Given this list of marker genes Mios, Sec13, Sik3, Gpr137 (G protein-coupled receptor 137), Ogt, Fnip2, Klhl22, Otub1, Rps6kb1, Tbk1, Lamtor4, Wac, Bmt2, Mat2a, Cul3 (cullin 3), Rbx1-ps, Slc38a9, Wdr59, Fnip1, Rheb, Ctns, Usp32, Rbx1, Pim1, Ep300, Otud5, Lamtor1, Flcn, Sesn2, Shq1, Stambpl1, Syk, Rragb, Gpr137c, Pih1d1, Srms, Lamtor5, Akt1, Rragc, Prmt1, Src, Lars1, Lamtor2 (NCBI Gene Id 83409), Pip4p1, Seh1l, Wdr24, Rragd (NCBI Gene Id 70641), Lamtor3, Rraga, Gpr137b, Csnk1a1, Usp4, Foxp1, Clec16a, Gpr155, Castor1, Rnf167, here is a description of the gene set: species: Mus musculus Any process that activates or increases the frequency, rate or extent of TORC1 signaling. Mouse Gene Set: GOBP_POSITIVE_REGULATION_OF_TORC1_SIGNALING